The following is a description of a gene set: from publication Amit I, Garber M, Chevrier N, Leite AP, Donner Y, Eisenhaure T, Guttman M, Grenier JK, Li W, Zuk O, Schubert LA, Birditt B, Shay T, Goren A, Zhang X, Smith Z, Deering R, McDonald RC, Cabili M, Bernstein BE, Rinn JL, Meissner A, Root DE, Hacohen N, Regev A (PMID 19729616) species: Homo sapiens Human Gene Set: GSE17721_POLYIC_VS_GARDIQUIMOD_0.5H_BMDC_UP Genes up-regulated in comparison of dendritic cells (DC) stimulated with poly(I:C) (TLR3 agonist) at 0.5 h versus DC cells stimulated with Gardiquimod (TLR7 agonist) at 0.5 h. mouse primary BMDCs were stimulated with tlr ligands and gene expression changes were profiled on Affymetrix arrays, and this is the list of marker genes: MRPS33, GJC2, RRM1, FGF10, ZKSCAN3, HOXC4, ELAVL3, NOX4, TBCE, LRRN1, ZNF474, STRBP, ELOC, TAF10 (TATA-box binding protein associated factor 10, NCBI Gene Id 6881), GABRA3, GJC1, EGFR, DVL2, SDSL, MAB21L2, SOX4, MAGEA11, TAS2R1, APOA2, CCR6, LMCD1, DCTN4, ID2, MAPK10, TMEM143, TNRC18, LINGO1, AUTS2 (NCBI Gene Id 26053), GFUS (GDP-L-fucose synthase), KRT23, PILRB, GPR88, RARB, NRCAM, ENPP1, TOMM40L, DPY30, CEMIP, SDF2, HAUS8, DENND2D (NCBI Gene Id 79961), RSPO1, SMC5, IGSF6, PROM2, PTH1R, ACKR3, CDCP1, KRT17, PLLP, KEL, PLG, KIAA1143, BPGM, CYP2C19, WNT11, NECTIN3 (NCBI Gene Id 25945), IFNA1, EN2 (NCBI Gene Id 8311), RACK1, KRTAP3-3, CAPZA3, SLC18A1, RUNDC3A, POU3F2, AKNA, INTS1, H1-10, MCM2, CD83 (NCBI Gene Id 9308), SUCO, PTH, PTGES, REST, EMID1, LCT, PRODH, UBXN1, KCNA5, PDZK1IP1, JMJD8, EPGN, CD160 (NCBI Gene Id 11126), RBBP9, C1QL1, SNX29, PTH2, DDR2, KLHL42, SWSAP1, GRHL2, FOXQ1, LIPF, GNG10, C6orf118 (NCBI Gene Id 353266), MAU2, HBZ, EPHX2, TRMT1, GDAP1, MYOZ1, TMEM119, CASP1, CDCA3, RPL30, CLASP2, CYP1B1, GADD45GIP1 (GADD45G interacting protein 1), CEP89, ZP3, VSIG2, NRBP1, FZD1, CHKA, NMRK1, BAIAP2, RTTN, SLC22A23, PWP2, DGKA, N4BP2L1, APOC1, THAP7, MYL9, CREBRF, GLIPR1, PIAS3, MAP2K1, NHERF4, ANGPTL1, KDM6A, SNRNP48, CBR1, PLA2G2D, HSPG2, PRMT1, RANBP1, NCAN, CMC2, QPCTL, ABCG2, ZBTB17, PTTG1IP, DNLZ, FRAT1, FIS1, COPE, HAAO, ANKRD54, STX8, SLC44A3, USP7, FAM86B2, TRHR (NCBI Gene Id 7201), GGT5, RBMS1, IQCC, ADCK1, ELP2, REXO2, PREB, GYPC, CEACAM21, SCRG1, FBXO2, RFNG (RFNG O-fucosylpeptide 3-beta-N-acetylglucosaminyltransferase), COMP, FANCE, MITF, RPS9, PPDPF, P4HA2, PYY, MTA1, CCNA1, ROPN1, PGM1, EYA2, FBXO36, TC2N, ALKBH3, PLA2G1B, PRRT1, BTF3, TAF4, TAMALIN, NBEA, ATXN1, WDR54, BOD1L1, HCN2, SYN2, MASTL (NCBI Gene Id 84930), ABCD2, CD28